The following is a description of a gene set: from publication Ludwiczek S, Theurl I, Muckenthaler MU, Jakab M, Mair SM, Theurl M, Kiss J, Paulmichl M, Hentze MW, Ritter M, Weiss G (PMID 17293870) Hereditary hemochromatosis and transfusional iron overload are frequent clinical conditions associated with progressive iron accumulation in parenchymal tissues, leading to eventual organ failure. We have discovered a new mechanism to reverse iron overload-pharmacological modulation of the divalent metal transporter-1 (DMT-1). DMT-1 mediates intracellular iron transport during the transferrin cycle and apical iron absorption in the duodenum. Its additional functions in iron handling in the kidney and liver are less well understood. We show that the L-type calcium channel blocker nifedipine increases DMT-1-mediated cellular iron transport 10- to 100-fold at concentrations between 1 and 100 microM. Mechanistically, nifedipine causes this effect by prolonging the iron-transporting activity of DMT-1. We show that nifedipine mobilizes iron from the liver of mice with primary and secondary iron overload and enhances urinary iron excretion. Modulation of DMT-1 function by L-type calcium channel blockers emerges as a new pharmacological therapy for the treatment of iron overload disorders. Genes changed in liver in response to nifedipine treatment of iron overload. studied in species Mus musculus Mouse Gene Set: LUDWICZEK_TREATING_IRON_OVERLOAD, and this is the list of marker genes: Hamp, Tfrc, Cp, Hpx, Mt2, Slc40a1, Lcn2